Given this list of marker genes Polq, Pole, Tent4b, Pot1b, Ptges3, Polg2, Poli, Pola2 (polymerase (DNA directed), alpha 2), Polk, Chrac1, Ptges3-ps, Pinx1, Pif1, Terc, Pold1, Pold3, Dntt, Polg, Tefm, Terf1, Ten1, Dkc1, Mcrs1, Primpol, Terf2, Tert, Polh, Polb, Poln, Tep1, Pcna, Rev3l, Pot1a, Pold4, Acd, Rev1, Polm (NCBI Gene Id 54125), Poll, Pola1, here is a description of the gene set: Catalysis of the reaction: a 2'-deoxyribonucleoside 5'-triphosphate + DNA(n) = diphosphate + DNA(n+1). Mouse Gene Set: GOMF_DNA_POLYMERASE_ACTIVITY species: Mus musculus